Given this list of marker genes HAX1, CELF1, SMARCB1, PMPCB, AKIRIN2, NUP62, ATP6V1H, NRCAM, MRPS25, BAIAP2, COQ9, REXO5, HPN, MFSD14A, DVL2, DNAJB2, RYR3, UTP3, CISH, AFF4, FIP1L1, BPNT1, COPE, KIF3B, PDCD2, PIP4K2A, PTPN2, COPS3, CLPTM1L, SCAMP1, PTPN23, ROCK2, WNT10B, CWC15, SLC35A2, LACTB2, TANK, MRPL9, ALG3, TBC1D24, CISD1, SERTAD1, POLR3K, UBE2S, GNPNAT1, SEPTIN7, SH3BGR, KTN1, CYP2A6, SRPK1, PRPF8, VMP1, PRPF39, SIGLEC1, AKAP8, MATR3, SENP6, TSR1, EFNA5, SYNGR2 (NCBI Gene Id 9144), MRPL45, THAP7, SLC25A4, GFRA1, STAM2, SMAP1, UBA3, IGF1, IRF7 (NCBI Gene Id 3665), GRPEL2, CDV3, FKBP5, SELENOK, CUEDC2, LRPPRC, ATP6AP2, PGAM1, RNF34, UBALD2, TSFM, INTS8, MRPS14 (mitochondrial ribosomal protein S14), SPAG5, ASAH1, CSRP1, ARF1, EMC2, RFK, ATN1, RPA3, GZMM, SAA1, CTSC, SLU7, PGM1, ADAMTS1, TIRAP, VAPA, LRBA, DCAF13, ACKR2, PRR15 (proline rich 15), CSTF2, POLR2J, PRMT1, CLP1, TALDO1, SLC22A12, POLR2F, IRF2BP1, THUMPD1, MRPL38, SMAD2, SEPTIN10, E2F5, NAB1, MIX23, CDCA5, COPZ1, RNF181, TEX2, KLF4, SPICE1, TTK, UBA7, ZNF274, ISG15, EIF3B, MSH3, ARFGAP3, NUTF2, MCM5, NUDT5, IRF8, TAGLN2, SLC22A6, MIF4GD, MRTO4 (MRT4 homolog, ribosome maturation factor), DDX19A (NCBI Gene Id 55308), PBX3, RBBP4, PRAF2, WDHD1, ATP6V1B2, CAPZA2, SERPINE2, PHLDA2, MPHOSPH10, RMND1, OGT, GCH1, DNAJB1, ARAP3, ATP5F1A, SEPHS2, PRMT3, RASA4, TNFRSF9, MTARC2, ABCB8, AQP2, ROCK1, TULP3, SLC30A1, IL1R1, SLC6A6, TBPL1, WWP2, MBD4, KANSL2 (NCBI Gene Id 80180), PRXL2A, HSPA5, OGFOD2, C6orf62, ZNHIT3, VEGFA, MRPL27, CCKAR, DEK, POLR3A, SAYSD1, ARPC5L, RBM26, IL1RAP, REEP6, PPIH, TBRG4, TXLNG, IL1RN, KDELR3, TCEA1 (NCBI Gene Id 7865), DNAJA3, YJU2B, AFG2A (NCBI Gene Id 170576), RAD23A, LGI4, MYCBP, NCOA1, ENO1, PSMB1, here is a description of the gene set: species: Homo sapiens from publication Agarwal P, Raghavan A, Nandiwada SL, Curtsinger JM, Bohjanen PR, Mueller DL, Mescher MF (PMID 19592655) Genes down-regulated in comparison of unstimulated CD8 T cells at 72 h versus CD8 T cells at 72 h after stimulation with antigen-B7-1. Differentiation of naive CD8 T cells into cytotoxic effector cells requires three distinct signals- antigen (signal 1), costimulation -B7-1 (signal 2) and cytokine, either interleukin-12 or interferon-a/b (signal 3). Interaction of naive CD8 T cells with antigen and B7-1 programs cell division and proliferation whereas the presence of cytokines- IL-12 or IFNa/b promote survival, differentiation and memory establishment. In the absence of signal 3, the cells interacting with antigen/B7-1 undergo tolerance induction. The objective of this study was to elucidate the mechanisms how the provision of signal 3 promotes differentiation and averts tolerance induction in CD8 T cells. Trichostatin A is a pharmacological agent that inhibits histone deacetylase activity, hence regulating chromatin structure and gene expression and differentiation in many cell types. Gene signature profiles of IL-12, IFNa/b and trichostatin A stimulated cells were compared to elucidate the molecular mechanisms of gene regulation. Oligonucleotide microarray analysis is carried out to determine the extent and molecular nature of the CD8 T cell differentiation program induced by IL-12 or IFNa/b in concert with antigen and B7-1 signal. Human Gene Set: GSE15930_STIM_VS_STIM_AND_IFNAB_72H_CD8_T_CELL_DN